The following is a description of a gene set: species: Homo sapiens Human Gene Set: GOMF_TAU_PROTEIN_BINDING Binding to tau protein. tau is a microtubule-associated protein, implicated in Alzheimer's disease, Down Syndrome and ALS., and this is the list of marker genes: PRKAA1, PIN1, PPP2R2A, ROCK2, FYN, PICALM, LGMN, TAOK2, EP300, HSPA2, S100B, CLU (NCBI Gene Id 1191), MARK1, HSP90AB1, PPP5C, GSK3B, DCTN1, TTBK1, STUB1, SNCA (synuclein alpha), MAP2, BRSK2, APOE, MARK2 (NCBI Gene Id 2011), GSK3A, PPP2CA, MAP1A, FKBP4, TAOK1, BRSK1, MARK4, CDK5, BAG2, BIN1, SMAD2, CREBBP (NCBI Gene Id 1387), HSP90AA1, ACTB, ROCK1, PPP2CB, HDAC6, DYRK1A (NCBI Gene Id 1859), TTBK2, MARK3